The following is a description of a gene set: Venezuelan equine encephalitis virus (VEEV) is a positive-strand RNA Alphavirus endemic in Central and South America, and the causative agent of fatal encephalitis in humans. In an effort to better understand the mechanisms of infection, including differences between people who produce a neutralizing antibody response to the vaccine and those who do not, we performed whole genome transcriptional analysis in human PBMCs exposed in vitro to the live-attenuated vaccine strain of VEEV, TC-83. We compared the molecular responses in cells from three groups of individuals: naive; previously vaccinated individuals who developed a neutralizing antibody response to the vaccine (responders); and those who did not develop a neutralizing antibody response to the vaccine (nonresponders). Overall, the changes in gene expression were more intense for the naive group after TC-83 challenge and least potent in the nonresponder group. The main canonical pathways revealed the involvement of interferon and interferon-induced pathways, as well as toll-like receptors TLR- and interleukin (IL)-12-related pathways. HLA class II genotype and suppression of transcript expression for TLR2, TLR4 and TLR8 in the nonresponder group may help explain the lack of vaccine response in this study group. Because TL3 and TLR7 transcripts were elevated in all study groups, these factors may be indicators of the infection and not the immunological state of the individuals. Biomarkers were identified that differentiate between the vaccine responder and the vaccine nonresponder groups. The identified biomarkers were contrasted against transcripts that were unique to the naive population alone upon induction with TC-83. Biomarker analysis allowed for the discernment between the naive (innate) responses; the responder (recall) responses; and the nonresponder (alternative) changes to gene transcription that were caused by infection with TC-83. The study also points to the existence of HLA haplotypes that may discriminate between vaccine low- and high-responder phenotypes. studied in species Homo sapiens from publication Erwin-Cohen R, Porter A, Pittman P, Rossi C, Dasilva L (PMID 22617845) Human Gene Set: ERWIN_COHEN_PBMC_TC_83_AGE_18_45YO_NON_RESPONDERS_PREVIOUSLY_IMMUNIZED_24HR_DEG_CANONICAL_PATHWAY_MEMBERS_DN Genes down-regulated in peripheral blood mononuclear cell 24h vs 0h in adults (18-45) (non-responders (previously immunized)) after exposure to Live attenuated vaccine TC-83, time point 24H. Comment: initial exposure 2-10 months before PBMCs drawn. significant genes chosen for membership in canonical pathways, and this is the list of marker genes: CEBPB, CCL7, CLEC7A, NLRC4, FOS (Fos proto-oncogene, AP-1 transcription factor subunit), TLR4, SPI1, C1QA, TLR8, TYROBP, C5AR1, ITGAX, CXCL8, C1QB (NCBI Gene Id 713), RXRA